The following is a description of a gene set: Genes up-regulated in comparison of dendritic cells (DC) stimulated with poly(I:C) (TLR3 agonist) at 2 h versus DC cells stimulated with Pam3Csk4 (TLR1/2 agonist) at 2 h. Human Gene Set: GSE17721_POLYIC_VS_PAM3CSK4_2H_BMDC_UP species: Homo sapiens from publication Amit I, Garber M, Chevrier N, Leite AP, Donner Y, Eisenhaure T, Guttman M, Grenier JK, Li W, Zuk O, Schubert LA, Birditt B, Shay T, Goren A, Zhang X, Smith Z, Deering R, McDonald RC, Cabili M, Bernstein BE, Rinn JL, Meissner A, Root DE, Hacohen N, Regev A (PMID 19729616) mouse primary BMDCs were stimulated with tlr ligands and gene expression changes were profiled on Affymetrix arrays, and this is the list of marker genes: HAUS3, POLR3A, DOLPP1, TM2D2, TRMT1L, ZKSCAN3, SCAF4, SERF2, WFS1, CDC37L1, CD200R1, CDC25A, SLC37A1, PPM1G, TMEM140, KCNK13, ENTPD4, TMEM268, XPR1, CDK2, SMYD2, RREB1, ORC5, RRP8, IL21R, MAP3K14, FAM8A1, NFIL3, AHRR, RASA1, CCL13, HASPIN, SH3BP2, SLAMF8, ZUP1, PPARGC1B, ASB13, MS4A6A, NECAP1 (NCBI Gene Id 25977), ACOX1, GLCCI1, ZYG11B, CLASP2, RAD1, MED23, LMBR1, DNMT1, PHF5A, CASP8AP2, RAB9A, UCHL5, ACOT8, TMEM192, SLC25A28, SNX19, NXF1, XBP1, SYS1, TRAF3IP2, ZNF322, NMNAT3 (NCBI Gene Id 349565), CNR2, ELF2, PIP4P2, RAI1, TMEM229B, VGLL4, DDHD2, TMEM134, INPP5D, SNX2, GYPC, CPTP, SMG5, EVI2A, ZSCAN21, SIRT7, DBF4 (NCBI Gene Id 10926), COX15, ZNF274, UBE2D1, PALD1, RAD51D, ATF1, TOR3A, CDK9, MGAT2, ZNF426, NUDT13, SLC44A2 (solute carrier family 44 member 2 (CTL2 blood group)), CEP68, SNX30, HLX, ANKMY2, UBE2L6, UQCC1 (ubiquinol-cytochrome c reductase complex assembly factor 1), SPEN, CEP350, INTS5, AFG2A, KIF2A, MED1, RXFP2, MAP4K1, CSTF1, THAP12, MRPL43, BRCC3, UBA7, ETFBKMT, ATPAF2, RAD54L (NCBI Gene Id 8438), IMP3, SCRIB, NEK7, DIPK2A, SESN1, CARD19, FIGNL1, SIKE1, ANKRD28, FBXW7, FGD2, ANAPC1, FAIM, TRIM39, MGA, CLASRP, NSMF, ARPC5L, UBE2R2, SNRK, BRPF1, MORC1, ATG3, POLK, MACIR, B4GALT6, AKIRIN2, LGALS3BP, PDGFC, MED22, FEZ2, MRPL35, ARMCX2, RSRP1, MAST3, PTGER2, NARF, MRPS23, INPP5E, GATC, SYNPO, RGCC, HBEGF, RBM18, TMEM51, UBE2G2, MX1, PAPOLG, PAGR1, NPRL2, MAFB, KMT2A, NEK9, JUN, BID, ETNK1 (ethanolamine kinase 1), DHX8, USP36 (ubiquitin specific peptidase 36), ZC3H8, NR2C2, MTMR10, ARMC10, FKBP1A, ATF6, MSL1, ATP13A1, NUDT16, SNHG8, ARHGEF7, ABCD2, UBAC1, CHST12, HMGXB4, IFFO1 (NCBI Gene Id 25900), PISD, BMAL1, SEZ6L2, DNAJA3, SKP2, USP38, CIAO1, NSMCE3, FAM3C, STX12, PITPNC1, AKAP10, KMT2E, OGFOD2